Given this list of marker genes Cpn1, Cpb1 (carboxypeptidase B1), Naalad2, Ace2 (angiotensin converting enzyme 2), Cpa6 (NCBI Gene Id 329093), Agbl5, Cpd, Cpa4, Matcap1, Cpz, Cpb2, Vash2, Agbl4, Folh1, Vash1, Agtpbp1, Prep, Cpe, Cpa2, Agbl2, Ace, Agbl3, Cpa1, Prcp, Cpa5, Cpm, Aebp1, Mme, Agbl1, Cpa3 (carboxypeptidase A3, mast cell), here is a description of the gene set: species: Mus musculus Catalysis of the hydrolysis of a single C-terminal amino acid residue from a polypeptide chain by a mechanism in which water acts as a nucleophile, one or two metal ions hold the water molecule in place, and charged amino acid side chains are ligands for the metal ions. Mouse Gene Set: GOMF_METALLOCARBOXYPEPTIDASE_ACTIVITY